The following is a description of a gene set: studied in species Mus musculus Mouse Gene Set: GOBP_ACTIN_FILAMENT_DEPOLYMERIZATION Disassembly of actin filaments by the removal of actin monomers from a filament., and this is the list of marker genes: Capg, Dbnl (drebrin-like), Sh3bp1, Scin, Cfl2, Actn2, Vil1, Mical1, Plek, Lima1, Plekhh2, Tpm1, Lmod1, F2rl1, Sptan1, Capzb, Pdxp, Mtpn, Avil, Shroom2, Capza1b, Add1, Aqp2, Ppp1r9b, Vill, Sptbn1, Lmod2, Gsn, Wdr1, Carmil2, Tmod2, Pik3ca, Cfl1, Specc1l, Flii, Tmod1, Rdx, Dmtn, Tmod4, Tmod3, Carmil1, Swap70, Arpc2, Svil, Mical3, Capza3, Lmod3, Capza2, Add3, Sema5a, Cracd, Capza1, Spta1, Twf2, Sptb, Twf1, Add2, Evl, Eps8, Dstn, Mical2, Myh9